The following is a description of a gene set: species: Homo sapiens Human Gene Set: GOMF_GLUTATHIONE_TRANSFERASE_ACTIVITY Catalysis of the reaction: R-X + glutathione = H-X + R-S-glutathione. R may be an aliphatic, aromatic or heterocyclic group; X may be a sulfate, nitrile or halide group., and this is the list of marker genes: MGST3, HPGDS, GSTO1, GSTM3, GSTA1, MGST2, GSTM4, SH3BGRL3, GSTA5, ALOX5AP, LANCL1, GSTT2, GSTK1, GSTP1, LTC4S, CLIC2, GSTT2B, GSTM2, GSTA3, GSTT4 (NCBI Gene Id 25774), GSTT1, GSTZ1 (NCBI Gene Id 2954), GSTM1, GSTO2, MGST1, GSTA4, GSTM5, GSTA2, PTGES